The following is a description of a gene set: Metatarsus valgus species: Homo sapiens A condition in which the anterior part of the foot rotates outward away from the midline of the body and the heel remains straight. Human Gene Set: HP_METATARSUS_VALGUS, and this is the list of marker genes: B3GALNT2, HSPG2, BMPR1B, DAG1, SIL1, FKRP, POMK, POMGNT1, CRPPA, POMT2, FKTN, POMT1, TGDS, GDF5, AKT1, LARGE1 (NCBI Gene Id 9215), NAA10, RXYLT1 (ribitol xylosyltransferase 1), POMGNT2, B4GAT1, COL4A1